The following is a description of a gene set: species: Homo sapiens Human Gene Set: MIR6129 Genes predicted to be targets of miRBase v22 microRNA hsa-miR-6129 in miRDB v6.0 with MirTarget v4 prediction scores > 80 (high confidence targets). from publication Chen Y, Wang X (PMID 31504780), and this is the list of marker genes: SNX33, ARHGAP19, RAB11FIP1, CCDC184, TOLLIP, DTX4, ZNF782, CDK1, SMAD3 (NCBI Gene Id 51521), EIF4EBP1, DCX, KLC4, SYNGAP1, KLK4, TTYH3, GTF2A1, AGAP1, FRY, KIF24, VCF2, SLC25A24, NEMP2, LASP1, CWC27, PAICS, LENG8, UBL4A, KCNQ4, RSPO4, MYCL, PACS1, SIGLEC1, MVB12B, KIAA0513, TMEM169, MAPKAPK2, RBMS3, NAA50, STUM, VTI1A, MSI1, TRIM16L (tripartite motif containing 16 like (pseudogene)), ENAM, SAMD9, SIX2, LDLRAD3, ADAM19, CHRDL1, BICDL1, ADGRF2P, KSR2, GMPPB, MMACHC, SMOC1, SDK1, INTS6, RNF169, FAM131C, RGSL1, ZNF583, TUBB, CACNG6, SORL1, IL2RG, TAB1, CENPP, KIF5A, NDST1, CERS3, LPXN, PTMS, WDTC1, LRATD2, F9, SMG6 (NCBI Gene Id 80091), PAK3, SLC9A8, BAZ2A, XYLB, HYCC2, ATP13A3, LURAP1, EYA3, SHLD1, LINC03040, LHX2, SLC19A3, NGEF, MPIG6B, SPINK14 (NCBI Gene Id 652690), NABP2, CLTA, JADE2, GJB3, PABPC1L2A, ELMOD1, SHE, MAPRE1, IGF1R, CANX, PLA2G2D (phospholipase A2 group IID), ACVR2A, ZNF703, TTBK1, DUSP26, PRR29, PSME3, FIGNL2, MAPK14, GPATCH8, DNMT3B, NOVA2, ETF1, SMIM24, PPP1R12B, GSK3A, PABPC1L2B (NCBI Gene Id 647480), SP1, IKBKE, CSNK1G1, BPIFB2, RASSF3, NXF1, NOL4L, AKAP13, FRMPD3, IL10RA, FOXL2NB, CREB3L1, GABRG2, STING1, PLXNA4, C20orf96, IL18R1, NUDT18, ZFPL1, FGD1, ABHD2, KRT75, CD34, RAB5B, NOTCH3, TRIM16, UBQLN2, ST3GAL1, XPR1, SHF, RCOR1, RPH3A, ARL8A, YEATS4, STX2, S100A16, OSBP, SHMT2, CERS2, DEFB118, NME9, NIPSNAP1, PIANP, CLSTN3, MIP (major intrinsic protein of lens fiber), ATAT1, MSH5, KDELR2, NFIX, ATP6V1B2, MICALL1, FBXO45, SPRY4, DNAH8, PARD3B, PADI2, POU2AF1, CAMKMT, SHB, CASTOR2, EXOC2, ALOXE3, NELFE, CDK5R2, ATP1B2, GEN1, ZNF395, MECP2, IGSF8, ERI3, KCNF1, DLX6, ALKBH1, TET3, BCL11A, KCND1, GATAD2B, IFFO1, SLC2A3, WBP2, NYNRIN